The following is a description of a gene set: Human Gene Set: HE_LIM_SUN_FETAL_LUNG_C2_PROMYELOCYTE_LIKE_CELL from publication He P, Lim K, Sun D, Pett JP, Jeng Q, Polanski K, Dong Z, Bolt L, Richardson L, Mamanova L, Dabrowska M, Wilbrey-Clark A, Madissoon E, Tuong ZK, Dann E, Suo C, Goh I, Yoshida M, Nikolić MZ, Janes SM, He X, Barker RA, Teichmann SA, Marioni JC, Meyer KB, Rawlins EL (PMID 36493756) Promyelocyte-like species: Homo sapiens, and this is the list of marker genes: CITED4, WEE1, RFLNB, CIP2A, SERPINB10, NT5DC2, CENPU, MLC1, CENPK, MPO, NUCB2, PRTN3, IGFBP2, UHRF1, NKG7, RNASE3, NCAPD2, PCLAF, PHGDH, CLEC11A, CENPF, RNASE2, UBE2C, ATAD2, HELLS, SLC2A4RG, MS4A3, KBTBD11, MCM2, RGL4, TOP2A, KCNE5, TYMS, MCM7, MCM4 (minichromosome maintenance complex component 4), MKI67, CDT1, CENPM, RRM1, HP, CTSG, AZU1, SERPINB8, GINS2, PRSS57, S100P, CLSPN, TIMELESS, TK1